The following is a description of a gene set: Any process that stops, prevents, or reduces the rate of differentiation of regulatory T cells. Mouse Gene Set: GOBP_NEGATIVE_REGULATION_OF_REGULATORY_T_CELL_DIFFERENTIATION studied in species Mus musculus, and this is the list of marker genes: Cd44, Irf1, Tnfsf4, Lag3, Ctla4, Mdk, Hspb1 (NCBI Gene Id 15507)